Given this list of marker genes FGF2, WNT1, MIR195, AKT1, FZD1, PYCR1, PARK7, IL10, HIF1A, PINK1, NONO, FBXO7, PRKN, CTNNB1, ATF4, here is a description of the gene set: Human Gene Set: GOBP_NEGATIVE_REGULATION_OF_OXIDATIVE_STRESS_INDUCED_NEURON_INTRINSIC_APOPTOTIC_SIGNALING_PATHWAY species: Homo sapiens Any process that stops, prevents or reduces the frequency, rate or extent of oxidative stress-induced neuron intrinsic apoptotic signaling pathway.